The following is a description of a gene set: A protein complex that spans a membrane and forms a water-filled channel across the phospholipid bilayer allowing selective monoatomic ion transport down its electrochemical gradient. Human Gene Set: GOCC_MONOATOMIC_ION_CHANNEL_COMPLEX species: Homo sapiens, and this is the list of marker genes: ATP5ME, KCNMB1, SMDT1, STAC3, CLDN4, GLRA2, OLFM2, RYR1, SCN3A, PTPA, KCNH3, KCNV2, GABRG3, KCNK6, TRPM4, TTYH3, CALM2, CLCNKB, KCNJ9, SLC26A6, LRRC55, CLIC5, ATP5MF, KCNK13, KCNG2, KCNMB2, KCNMB3, KCNH7, GABRD, GPR89B, CACNG2, SCN2A, KCNE2, KCNAB1, KCNIP1, ABHD6, C2CD6, CHRNA1, KCNMA1, CACNA1H (NCBI Gene Id 8912), KCNJ15, DPP10, ANO1, TRPC6 (NCBI Gene Id 7225), GRIN2A, CACNG7, ATP5MC2, KCNJ18, MICU3, GRIK1, ATP5PF, MCU, CACNB3, CNIH3, CACHD1, SCNN1A, KCND3, CATSPERG, CACNA1C, GRID2, UNC80, GABRB1, CACNA1G, CHRNA4, KCNS1, HCN1, SCN1A, GABRE, EPS8, KCNK7, PACC1, ATP5MC3, CLCN7, LRRC8E, PKD1L3, ATP5F1B, TTYH1, KCNJ2, KCNC3, CALM1, AKAP6, KCNJ11, TRPC7, CLDN17, KCNE5, ATP5F1C, GRIA2, KCNJ5, CLCC1, CACNA1S, ANO2, GLRA3, LRRC8B, ANO6, SCN2B, KCNG3, CATSPER1, KCNN4, HCN3, KCNA5, SHISA8 (NCBI Gene Id 440829), CNGB3, KCNMB4, KCNA4, KCNA1 (NCBI Gene Id 729214), CHRNA5, KCNF1, HSPA2, HTR3E, GRIN2B, TRPC3, CNGA3 (cyclic nucleotide gated channel subunit alpha 3), VWC2, GABRG2, KCNJ6, CATSPERB, KCNQ5 (potassium voltage-gated channel subfamily Q member 5), ASPH, CACNA1B, GPR89A, VAMP2, KCNK16, CACNG8, CACNA1I, CHRNA7, ATP5F1E, RYR3, SHISA6, BEST2, CACNB2, SLC17A7, PKD2L1, SCN5A, PRKACA, CACNG1, KCNG1, CATSPER4, KCNB2 (NCBI Gene Id 9312), MFSD8, ATP5MC1, GABRA1, SCN10A, CHRNB3, KCNS3, GRIA4, HTR3B, EFCAB9, ATP5PD, ATP5PB, GRIN2C, PORCN, ATP5MGL, ATP5MK, LRRC38, KCNJ8, SLC17A6, KCNK4, ABCC9, HTR3C, BEST3, GABRA6, KCNJ12, CHRNB1, KCNH2, CNIH2, CACNA1E, LRRC8C, KCNE4, SCNN1G, GRIK2, SCN9A, GLRA1, CHRND, MT-ATP6, KCNK5, SCN4B (NCBI Gene Id 6330), CACNG5, AKAP9, KCNB1, CLCN2, KCNIP3, KCNK12, DMAC2L, KCNE1, CACNA1A, MICU1, TMEM249, GRID1, GRIN3A, CACNG6, GRIK5, OLFM3, OSTM1, TRPC5, CALM3, ATP5MJ, CACNG4, GRIK3, CHRNB4, PKD1L1 (NCBI Gene Id 168507), CACNG3, KCNA3, SACM1L, GABRR1, KCNK1 (NCBI Gene Id 3775), TRPM5 (NCBI Gene Id 29850), KCNA7, TTYH2, KCND1, CACNA2D3, CACNB1, KCNJ3, DPP6, CLIC6, KCNJ16, NRN1, KCNC1, TRPV6, KCNS2, KCNA2, MCUB, KCNK15, BEST4, HCN2, RYR2, SCN1B, GRIK4, KCNA6, ATP2A1, CNGB1, KCNQ2, LRRC8A, TMEM37 (NCBI Gene Id 50627), CHRFAM7A, CLIC1, GABRR3, GABRA2, CNGA2, BEST1, KCNIP4, KCNA10, CNTNAP2, GABRR2, GABRA3, CLIC3, ABCB8, PKD2, TRPC1 (NCBI Gene Id 7220), TRPC4, KCNJ13, KCNU1, TMEM109, SHISA7, ORAI1, PDE4B, GRIA1, CACNA1F, CACNB4, MT-ATP8, PDE4D, GABRB2, GABRA5, PTK2B, CHRNB2, CHRNE, DLG2, KCND2, KCNQ4, KCNE3, CHRNA3, TRPV5, CYBB (NCBI Gene Id 1536), GABRG1, CLIC2, KCNK10, KCNH8, GLRB, KCNV1, KCNN1, KCNJ14, SESTD1, GRIA3, FKBP1B, HCN4, KCNH5, GRIN1, GRIN3B, CASQ2, CLIC4 (chloride intracellular channel 4), CHRNG, KCNH6, SLC17A8, SCN11A, DLG4, KCNK17, KCNG4, CATSPER3, GABRP, HTR3D, VWC2L, KCNC4, CATSPER2, GABRA4, KCNJ1, HVCN1, CATSPERD, SHISA9, KCNH4, GABRB3, STXBP5, ABCC8, CNGA1, KCNC2, CCDC51, KCNJ4, KCNQ3, CTTN, KCNAB3, ATP5F1EP2, SNAP25, STX1A, MICU2, FKBP1A, LRRC8D, CNGA4, SCN3B, KCNK2, CPT1C, TMEM262, ATP5F1A, KCNH1, HTR3A, CACNA2D2, CHRNA6, GABRQ, KCNIP2, CHRNA2, AMIGO1, TPCN1, CATSPERZ, SUMO1, ATP5F1D, SCNN1D, ATP5MG, CACNA2D4, KCNAB2, CLCN1, CACNA2D1, SCN4A, DLG3, KCNJ10, ATP5PO, SCN8A, ABHD12, CFTR, NALCN, SCNN1B, LRRC52, CATSPERE, CHRNA9, CACNA1D, CLCNKA, PKD1, LRRC26 (NCBI Gene Id 414321), KCNQ1 (potassium voltage-gated channel subfamily Q member 1), TPCN2, GRIN2D, SCN7A